Given this list of marker genes AQP3, UMOD, HBB, HBD, RHBG, HBG1, RHAG, HBZ, AQP8, POU3F3, AQP6, UPK3A, HBG2, RHCG, HBA2, HBA1, CA2, SLC14A1, AQP9, AQP1, AQP5, AQP7, SLC14A2, HBE1, AQP11, here is a description of the gene set: Human Gene Set: GOBP_ONE_CARBON_COMPOUND_TRANSPORT The directed movement of one-carbon compounds into, out of or within a cell, or between cells, by means of some agent such as a transporter or pore. species: Homo sapiens